The following is a description of a gene set: Mouse Gene Set: REACTOME_ANTIGEN_ACTIVATES_B_CELL_RECEPTOR_BCR_LEADING_TO_GENERATION_OF_SECOND_MESSENGERS species: Mus musculus Antigen activates B Cell Receptor (BCR) leading to generation of second messengers, and this is the list of marker genes: Ighv3-5, Pik3ap1, Ighv8-12, Sh3kbp1, Igkv11-125, Ighv3-6, Igkv1-122, Ighv7-2, Pik3r1, Igkv20-101-2, Itpr3, Pik3cd (NCBI Gene Id 78494), Ighv5-2, Igkv1-99, Cd79b, Ighv6-3, Igkv2-109, Ighv13-2, Nck1, Igkv17-121, Ighv8-6, Igkv1-132, Ighv5-4, Ighd, Igkv1-117, Plcg2, Cd19, Ighv6-6, Ighv5-15, Igkv16-104, Igkv8-21, Itpr1, Ighv5-9-1, Ighv8-5, Itpr2, Ighv5-12, Iglc2, Ighv5-9, Ighv6-5, Ighv8-13, Ighv8-2, Ptpn6, Ighv5-16, Ighv8-9, Ighv12-3, Vav1, Sos1, Iglc1, Igll1, Trpc1, Igkv2-137, Igkv2-112, Igkv1-110, Ighv3-3 (immunoglobulin heavy variable V3-3), Syk, Igkv1-35, Ighv6-4, Ighv3-4, Stim1, Igkv1-135, Igkv18-36, Ighv8-4, Ighv5-12-4, Ighv8-8, Ighv8-11, Dapp1, Ighv3-8, Ighv16-1, Cd79a, Igkv1-88, Igkv1-131, Ighv5-17, Ighv6-7, Igkv15-103, Igkv1-133, Ighv3-1 (NCBI Gene Id 780803), Ighv7-3, Ighv5-6, Blnk, Grb2, Cd22, Btk, Ighv7-4